Given this list of marker genes Ak7, Ak4, Cmpk1, Ak8, Cmpk2, Ak9, here is a description of the gene set: Catalysis of the reaction: ATP + (d)CMP = ADP + (d)CDP. species: Mus musculus Mouse Gene Set: GOMF_D_CMP_KINASE_ACTIVITY